The following is a description of a gene set: Pathway Definition from KEGG: WNT -> (FZD7*+LRP5/6) -> (DVL+FRAT) -| (GSK3B+AXIN+APC) -| CTNNB1 -> TCF/LEF => (MYC,CCND1) studied in species Homo sapiens FZD7-overexpression to Wnt signaling pathway. Pathway ID: N00059. Pathway type: Variant. Pathway class: nt06263 Hepatocellular carcinoma. Human Gene Set: KEGG_MEDICUS_VARIANT_FZD7_OVEREXPRESSION_TO_WNT_SIGNALING_PATHWAY, and this is the list of marker genes: WNT2B, WNT8A, WNT5B, WNT6, DVL1, WNT7A, WNT7B, LRP5, WNT3, GSK3B, WNT10B, AXIN1, WNT9A, AXIN2, WNT16 (Wnt family member 16), WNT4, FRAT2, DVL3, FZD7, WNT9B, CCND1, WNT10A, LRP6 (LDL receptor related protein 6), APC, TCF7, WNT3A, WNT1, TCF7L1, FRAT1, LEF1, WNT5A, MYC, CTNNB1, DVL2, WNT2, WNT8B, TCF7L2